The following is a description of a gene set: Mouse Gene Set: GOBP_MICROGLIAL_CELL_PROLIFERATION studied in species Mus musculus The expansion of a microglial cell population by cell division., and this is the list of marker genes: Gba1, Csf1r (NCBI Gene Id 12978), Il33, Il34, Cx3cl1, Ndp, Trem2, Clu, Csf1